The following is a description of a gene set: Any process that activates or increases the frequency, rate or extent of nuclear division, the partitioning of the nucleus and its genetic information. studied in species Homo sapiens Human Gene Set: GOBP_POSITIVE_REGULATION_OF_NUCLEAR_DIVISION, and this is the list of marker genes: LRP5, MAD2L1BP, OOEP, PLCB1, TGFA, BTC, MSX1, PDGFRB, EREG, PHIP, IGF1, MAD1L1, EDN3, WNT4, CDC20, SKA1, MSX2, ANAPC5, INSR, NUSAP1, TNF, DAZL, FGF8, HOXA13, NSMCE2, WNT5A, PIWIL2, ANAPC11, NUP62, INS, IL1A, STRA8, SH2B1, IL1B, NPM2, EGF, SIRT2, EDN1, UBE2C, RAD51AP1, CDC23, CUL3, ESPL1, PRDM9, SMPD3, DRD3, DMRT1, CD28, MEIOSIN, PDGFB, RB1, SKA3, UBE2B, NPR2, IGF2, PRAP1, SPHK1, ANAPC7, CDC16, DLGAP5 (DLG associated protein 5), EPGN, AURKA